Given this list of marker genes S100A9, S100B, FCGR3A, IGFBP7, MT2A, HLA-B, SELL, MYOM2, here is a description of the gene set: Thirty-eight PBMC samples from 25 patients with IPF and 13 matched controls yielded 149,564 cells that segregated into 23 subpopulations. Classical monocytes were increased in progressive and stable IPF compared to controls (32.1%, 25.2%, 17.9%, respectively, p<0.05). Total lymphocytes were decreased in IPF vs controls, and in progressive vs stable IPF (52.6% vs 62.6%, p=0.035). Tregs were increased in progressive vs stable IPF (1.8% vs 1.1% of all PBMC, p=0.007), although not different than controls, and may be associated with decreased survival (P=0.009 in Kaplan-Meier analysis; P=0.069 after adjusting for age, sex, and baseline FVC). Flow cytometry analysis confirmed this finding in an independent cohort of IPF patients. Fraction of Tregs out of all T cells was also increased in two cohorts of lung scRNA-seq. CCL22 and CCL18, ligands for CCR4 and CCR8 Treg chemotaxis receptors, were increased in IPF. The single-cell atlas of the peripheral immune system in IPF, reveals an outcome-predictive increase in classical monocytes and Tregs, as well as evidence for a lung-blood immune recruitment axis involving CCL7 (for classical monocytes) and CCL18/CCL22 (for Tregs). (From Abstract) species: Homo sapiens Human Gene Set: UNTERMAN_PROGRESSIVE_VS_STABLE_IPF_NK_CELL_UP Genes upregulated in NK cells from Progressive Idiopathic Pulmonary Fibrosis Patients vs. Stable Non-Progressors from publication Unterman A, Zhao AY, Neumark N, Schupp JC, Ahangari F, Cosme C Jr, Sharma P, Flint J, Stein Y, Ryu C, Ishikawa G, Sumida TS, Gomez JL, Herazo-Maya JD, Dela Cruz CS, Herzog EL, Kaminski N (PMID 38717443)